The following is a description of a gene set: High-throughput characterisation of the molecular response of pulpal tissue under carious lesions may contribute to improved future diagnosis and treatment. To identify genes associated with this process, oligonucleotide microarrays containing approximately 15,000 human sequences were screened using pooled total RNA isolated from pulpal tissue from both healthy and carious teeth. Data analysis identified genes with 2-fold or greater difference in expression level, with 85 more abundant in health and 360 more abundant in disease. Subsequent gene ontological grouping identified a variety of processes and functions potentially activated or down-modulated during caries. Validation of microarray results was obtained by a combination of real-time and semi-quantitative PCR for selected genes, confirming down-regulation of Dentin Matrix Protein-1 (DMP-1), SLIT 2, Period-2 (PER 2), Period-3 (PER 3), osteoadherin, Glypican-3, Midkine, activin receptor interacting protein-1 (AIP 1), osteoadherin and growth hormone receptor (GHR), and up-regulation of Adrenomedullin (ADM), Interleukin-11 (IL-11), Bone sialoprotein (BSP), matrix Gla protein (MGP), endothelial cell growth factor-1 (ECGF 1), inhibin beta A and orosomucoid-1 (ORM 1), in diseased pulp. Real-time PCR analyses of ADM and DMP-1 in a panel of healthy and carious pulpal tissue and also in immune system cells highlighted the heterogeneity of caries and indicated increased expression of ADM in neutrophils activated by bacterial products. In contrast, DMP-1 was predominantly expressed by cells native to healthy pulpal tissue. This study has greatly extended our molecular knowledge of dental tissue disease and identified involvement of genes previously unassociated with this process. Human Gene Set: MCLACHLAN_DENTAL_CARIES_UP from publication McLachlan JL, Smith AJ, Bujalska IJ, Cooper PR (PMID 15869869) studied in species Homo sapiens Genes up-regulated in pulpal tissue extracted from carious teeth., and this is the list of marker genes: PIM2, PLA2G7, SLC46A3, APOC1, SLA, SRGN, SLAMF8, CYRIB, TREM1, ADAMDEC1, F13A1, BCL3, IGHV3-21, SAA1, ALOX5AP, ITGB2 (NCBI Gene Id 3689), SPP1, RGS2, LRCH4, CHI3L1, CHI3L2, SERPINA1, CCL8, C1QA, LBP, NCF4, IGLC2, IGKV4-1, TRIB1, HCLS1, LCP2, CYP1A1, CRLF1, LY96, POU2AF1 (POU class 2 homeobox associating factor 1), HLA-DPA1, TNFAIP8, IGHV4-61, REEP1, MS4A6A, MT1G, GLRX, IGKV1D-17, C5AR1, PTPRC, RAB29, SERPINA3 (NCBI Gene Id 95022), C4A, JCHAIN, NNMT, PAX5, IGKV3-20, SOD2, RAB31, TNFRSF21, C3, IGHV3-20, SERPINB2, SKAP2, MS4A1, EVI2A (ecotropic viral integration site 2A), CLEC2B, CFB, CXCL8, TIMP1, CCL5, ORM1, CLEC7A, LTB, IGHV3-23, SAT1, CCL3, SAMSN1, MMP1, CCR1, IGHG1, HLA-DPB1 (major histocompatibility complex, class II, DP beta 1), PTGS2, MCL1, WARS1, CYTIP, FCGR2B, MAN2B1, CHL1, ACP5, SLPI, CRYBG1, HLA-DQA1, CEBPD, TENT5C, CSF2RB, IGKV1D-37, DDX3Y, MT1X, HLA-DRB1, IER3, MS4A4A (membrane spanning 4-domains A4A), CORO1A, PTP4A3, FPR1, STAB1, TRBC1, IGHM, IGHA1, BCL2A1, MAFF, PECAM1 (NCBI Gene Id 5175), UCP2, HLA-DMB, CSF1R, GZMB, CD48, NAMPT, CD209, FCER1G, CXCL5, RPS4Y1, IGKV2D-28, TNFAIP3, IGKV1OR2-108, CD55, MTHFD2, ACSL1, SOCS3, HLA-DQB1, SLC7A11, HCAR3, PTGER4, EVI2B, ARPC1B (NCBI Gene Id 10095), CTSB, VCAM1, CXCL12, SELE (selectin E), CXCR4, CA12, CD79A, ABCA1, ALOX5, THBS4, FGL2 (fibrinogen like 2), CAPG, CD93, HLA-DMA, CD4, ARHGDIB, CTSS, DEPP1, TNFRSF1B, IBSP, IGLL3P, NAP1L1, CXCL13, C3AR1, CD74, IL1RN, FYB1, SFRP4 (secreted frizzled related protein 4), CXCL9, RAC2, LYN, SORL1, CHST15, INHBA, CFI, RNASE1, ANGPTL2, IFI30, CD1D, MZB1, LSP1, S100A8, HBB, TNFAIP6, CD84, ACKR1, GABBR1, LYZ, IRF4, C1QB, IL7R, MSR1, FKBP11, BIRC3, SSR4, RNASE6, VAMP8, CXCL1, IGHV1-69, NFIL3, MT2A, HLA-DRB4, IL13RA1, FCN1, LRRC15, PLAU, AQP3, SERPINE2 (NCBI Gene Id 5270), FCGR3B, COL15A1, CCL2, TYROBP, CYBB, BLNK, PLAUR, IGFBP4, LCP1, SASH3, HCK, FCGR2A, IGKV1D-39 (NCBI Gene Id 28893, immunoglobulin kappa variable 1D-39), IL10RA, CD44, ANPEP, IL11, CCR2, ADM, MRC1, IGKV1D-13, HLA-DRA, G0S2, IL1B, CD163, MMP9, SLC2A3, CFD, TRBC2, EIF1AY, CD53, MNDA, IGLV2-14, C1QL1, LAPTM5, APOE, IGFLR1, CPVL, SCO2, CTSC, CCL18, PLAC8, IL6, SLC1A4, NCF2, ICAM1, KDM5D, TYMP, IGKC (immunoglobulin kappa constant), HLA-DRB6, PI3, MGP, S100A9, CD14, CTSH, CYBA, IRF8 (interferon regulatory factor 8), KYNU, ADA2, IGKV1OR1-1, CD27 (NCBI Gene Id 939), KPNA2, GPNMB, CD37, PLEK, SEL1L3